Given this list of marker genes CCL19, SPI1, CCR7, CCL21, ARHGEF5, here is a description of the gene set: The movement of a myeloid dendritic cell in response to an external stimulus. species: Homo sapiens Human Gene Set: GOBP_MYELOID_DENDRITIC_CELL_CHEMOTAXIS